Given this list of marker genes ADAMTS1, SELE, MCL1, APOLD1, BMP2, NR4A2, GEM, CXCL2, ATF3, CXCL8, NDRG1, SIK1, NR4A3, CITED2, CCN1, ZFP36, KLF2, CREM, F3, RCAN1, DUSP1, NEDD9, ELL2, PTGS2, NR4A1, PDK4, HBEGF, KLF4, EGR3, EGR1, RGS2, HLX (NCBI Gene Id 3142), KCNJ2, ARID5B, FOSL2, MAP3K8 (NCBI Gene Id 8040), here is a description of the gene set: Genes up-regulated in HUVEC cells (primary endothelium) after stimulation with leukotriene LTD4 or thrombin (F2) for 1 h. Human Gene Set: UZONYI_RESPONSE_TO_LEUKOTRIENE_AND_THROMBIN Cysteinyl leukotrienes (cysLT), i.e., LTC4, LTD4, and LTE4, are lipid mediators derived from the 5-lipoxygenase pathway, and the cysLT receptors cysLT1-R/cysLT2-R mediate inflammatory tissue reactions. Although endothelial cells (ECs) predominantly express cysLT2-Rs, their role in vascular biology remains to be fully understood. To delineate cysLT2-R actions, we stimulated human umbilical vein EC with LTD4 and determined early induced genes. We also compared LTD4 effects with those induced by thrombin that binds to protease-activated receptor (PAR)-1. Stringent filters yielded 37 cysLT2-R- and 34 PAR-1-up-regulated genes (>2.5-fold stimulation). Most LTD4-regulated genes were also induced by thrombin. Moreover, LTD4 plus thrombin augmented gene expression when compared with each agonist alone. Strongly induced genes were studied in detail: Early growth response (EGR) and nuclear receptor subfamily 4 group A transcription factors; E-selectin; CXC ligand 2; IL-8; a disintegrin-like and metalloprotease (reprolysin type) with thrombospondin type 1 motif 1 (ADAMTS1); Down syndrome critical region gene 1 (DSCR1); tissue factor (TF); and cyclooxygenase 2. Transcripts peaked at approximately 60 min, were unaffected by a cysLT1-R antagonist, and were superinduced by cycloheximide. The EC phenotype was markedly altered: LTD4 induced de novo synthesis of EGR1 protein and EGR1 localized in the nucleus; LTD4 up-regulated IL-8 formation and secretion; and LTD4 raised TF protein and TF-dependent EC procoagulant activity. These data show that cysLT2-R activation results in a proinflammatory EC phenotype. Because LTD4 and thrombin are likely to be formed concomitantly in vivo, cysLT2-R and PAR-1 may cooperate to augment vascular injury. from publication Uzonyi B, Lötzer K, Jahn S, Kramer C, Hildner M, Bretschneider E, Radke D, Beer M, Vollandt R, Evans JF, Funk CD, Habenicht AJ (PMID 16606835) studied in species Homo sapiens